The following is a description of a gene set: Catalysis of the reaction: a 1,2-diacyl-sn-glycero-3-phospho-(1D-myo-inositol-4,5-bisphosphate) + H2O = 1D-myo-inositol 1,4,5-trisphosphate + a 1,2-diacyl-sn-glycerol + H+. species: Homo sapiens Human Gene Set: GOMF_PHOSPHATIDYLINOSITOL_4_5_BISPHOSPHATE_PHOSPHOLIPASE_C_ACTIVITY, and this is the list of marker genes: PLCD4, PLCH1, PLCB4 (phospholipase C beta 4), CHRM3, CASR, CHRM1, PLCG1, PLCL1, PLCD3, EDNRA, PLCB1, PLCL2, BDKRB2, PLCH2, PLCB3, PLCD1, PLCB2, CCL5, CCR1, PLCG2, F2RL2, CHRM5, GDPD5, CCR5, PLCZ1, PLCE1